Given this list of marker genes Zfhx3, Mup11, Mup2, Ncor1, Mta1 (NCBI Gene Id 116870), Id2, Mtor, Kcnma1, Ncoa2, Pten, Mc3r, Cntnap2, Nms, Mup1, Mup3, Oprl1, Usp2, Npas2, Naglu, Rogdi, Mapk10, Ciart, Egr1, Mup5, Kcnd2, Ankfn1 (NCBI Gene Id 382543), Mup4, Lepr, Pln, here is a description of the gene set: studied in species Mus musculus Mouse Gene Set: GOBP_LOCOMOTOR_RHYTHM The rhythm of the locomotor activity of an organism during its 24 hour activity cycle.